The following is a description of a gene set: Genes up-regulated in HEK293 cells (embryonic kidney) at 6 h, 12 h or 24 h after infection with reovirus strain T3A (known as a strong inducer of apoptosis). Human Gene Set: DEBIASI_APOPTOSIS_BY_REOVIRUS_INFECTION_UP from publication DeBiasi RL, Clarke P, Meintzer S, Jotte R, Kleinschmidt-Demasters BK, Johnson GL, Tyler KL (PMID 12885910) studied in species Homo sapiens Reoviruses are a leading model for understanding cellular mechanisms of virus-induced apoptosis. Reoviruses induce apoptosis in multiple cell lines in vitro, and apoptosis plays a key role in virus-induced tissue injury of the heart and brain in vivo. The activation of transcription factors NF-kappaB and c-Jun are key events in reovirus-induced apoptosis, indicating that new gene expression is critical to this process. We used high-density oligonucleotide microarrays to analyze cellular transcriptional alterations in HEK293 cells after infection with reovirus strain T3A (i.e., apoptosis inducing) compared to infection with reovirus strain T1L (i.e., minimally apoptosis inducing) and uninfected cells. These strains also differ dramatically in their potential to induce apoptotic injury in hearts of infected mice in vivo-T3A is myocarditic, whereas T1L is not. Using high-throughput microarray analysis of over genes, we identified differential expression of a defined subset of genes involved in apoptosis and DNA repair after reovirus infection. This provides the first comparative analysis of altered gene expression after infection with viruses of differing apoptotic phenotypes and provides insight into pathogenic mechanisms of virus-induced disease., and this is the list of marker genes: TAF1A, TMCC1, PIR (pirin), SYF2, IFI27, CD55, IFI44L, IFIT3 (interferon induced protein with tetratricopeptide repeats 3), BUB3, IFITM3 (interferon induced transmembrane protein 3), FHL2, CEBPB, FGF2, KRR1, IFI6, CREB5, SP100, DCTN6, CEP43, TGDS, PGAM1, DUSP3, PDCL, PLK4, CRK, OLIG2, CDK17, LINC00222, CLK1, FGF9, SP1, CXCL2, ZNF254, H2BC6, EIF4E, JUN, TAC1, TIAL1, IFRD1, MID1, BTG3, EYA4, SNAPC1, EGR3, BCL6, DNAJB9, CXCL10, AKAP10, SOCS6, GPN1, CASP3, ZBTB18, PANK3, ZNF184, NMI, IRF9, COX6A1, RAB5A, POLR3F (RNA polymerase III subunit F), OGFR, RWDD3, CCDC6, SHOC2, ZNF516, OTUD3, PAWR, BHLHE40, FAF2, H2AC13, PDE4D, FOXJ3, SAMHD1, SHOX2, H2AC20, LSM6, DHX9, DHRS2, BAZ2B, BLZF1, KIN, DUSP8, UBE2V2, ZNF217, PLSCR1, ZWINT, OSER1, IFNB1, H2BC7, BCL10, GEMIN2, ZZZ3, INSM1, CPEB3, TNFAIP3, TAF1C, UBE2L6, HSPA1L, MED13L, HRK, PSMB9, ABRAXAS2, AK2 (NCBI Gene Id 83165), PEX13, N4BP1, CREM, DNAJB6, ATF6, TBPL1, WEE1, DNAJC2, POLR2M, TIPARP, TLK1, PRKAA1, TRIM22, RND3, CD2AP, THAP12, CEBPG, OAS2, HOXA5, ARPP19, MED21, NLE1, ZFX, ZBTB20, PPAT, SMAD5 (NCBI Gene Id 4090), GTF2H2, BET1, MBTPS2, UBE2D1, CHEK1, GINS1, ADM, ZNF239, KPNA5, YAP1, UGCG, MAP3K1, RBMS1P1, H2AC18, FXR1, PCK1, NECAP1, STK17B, SLC3A2, GEM, ZNF24 (zinc finger protein 24), RRS1, RBM15B, POLR1F, PRP4K, CREBZF, ANAPC10, CLK3, ZNF623, PNO1, PPM1A, GNAQ, SNRK, MOB4, IFI35, PMAIP1, BCL2L2 (BCL2 like 2), IFIT5 (interferon induced protein with tetratricopeptide repeats 5), EIF2B5, MKLN1, ARHGAP5, PFDN4, SECISBP2L, NUFIP1P1, WASL, AGFG1, CETN3, TAP1, UBE2H, ZBTB6, CXCL1, RLF, RCHY1, FBXO28, NF1 (NCBI Gene Id 646021), KLF6, BRCA1, MAP4K5, GNAI1, IFI44, OASL, SREBF1, LSM5, ISG15, NEK7, ZNF330, SLC25A16, CCN2, STX3, PPP1R15A, IREB2, TDRD7, STAT1, CCL5, TIMM17A, NRAS, RAD51AP1, UBA3, WASHC4, ZC3HAV1, TM2D1, YTHDC1, KAT5, ID4, GABARAPL1, TBC1D9, NUP98, ZNF292, THUMPD1, MX2, RAD1, ACSM3, RAB11FIP2, ATF1, H2BC11, ZNF189, ANXA1, ZFP36, NRIP1, IFI16, MCL1, NFKBIA, CELF1, DUSP1, CAP2, TAF5, MAP2K4, RRAS2, MAK16, GBP1, GNA13, ZNF44, BNIP1, NR4A2, PITPNB, H1-0, DTNA, SMIM8, RYBP, SMNDC1, CDC27, PTPN2, RCAN1, DYRK1A (NCBI Gene Id 1859), IRF7, HOXD4, RSRC2, SPRY1, NHLH2, COPS2, CAPZA2, ATF3, ISG20, CXCL11, RPE, OTUD4, ZNF529, ZNF264, BRAP, RAB3GAP1, RNMT, ATXN3, GULP1, SPATA2, BST2, GADD45A, SLC2A3, CCP110, PPP3CB, E2F6, TRIM21, STRN3, ZNF518A (zinc finger protein 518A), CCN1, NR1D2, USP9X, TADA2A, RAB21 (RAB21, member RAS oncogene family), ABI2, CXCL8, OAS1, CCNE2 (cyclin E2), PML, H2BC10, SIKE1, WTAP, NUP58, ZEB2, BACH1, TRPC1 (NCBI Gene Id 7220), ITCH, IFITM1